The following is a description of a gene set: A multisubunit complex comprising the chaperonin-containing T-complex and several other components involved in mediating sperm-oocyte Interaction. Mouse Gene Set: GOCC_ZONA_PELLUCIDA_RECEPTOR_COMPLEX species: Mus musculus, and this is the list of marker genes: Zpbp, Zpbp2, Tcp1, Cct5, Cct2, Zp3r, Cct4, Cct3, Cct8, Hspa1b, Cct7, Cct6a, Hspa1l (NCBI Gene Id 15482)